The following is a description of a gene set: Any process that activates or increases the frequency, rate or extent of lipid localization. Mouse Gene Set: GOBP_POSITIVE_REGULATION_OF_LIPID_LOCALIZATION studied in species Mus musculus, and this is the list of marker genes: Nucb2, Ces1h, Ces1c, Washc1 (WASH complex subunit 1), Cyp4a31, Tac1, Abca1, Apoa1, Oxt, Scp2, Ces1d, Abcg4, Plin2, Ikbke, Lrat, Ces1f, Edn1, Avpr1b, Hrh3, Crh, Vstm2a, Runx1, Srebf2 (NCBI Gene Id 20788), Abcg1 (ATP binding cassette subfamily G member 1), Myb, Tnfrsf11a, Ldlrap1, Mapk9, Abca8b, Pla2g10, Zc3h12a, Pla2g4a, Pla2g3, Abca5, Asxl2, Pon1, Scarb1, Msr1, Atp8a2, Plin3, Zdhhc8, Ghrl, Ptch1, Nkx3-1, Dab2, Trem2, Ces1g, Nmb, Abca7 (NCBI Gene Id 27403), Apob, Lpl, Lpcat3, Atp8a1, Ces1b, Tnfsf11, Retn, C1qtnf1, Ntsr1, Dennd5b, Prap1, Acsl5, Nr1h3, Sirt1, Acsl1, Cyp2j5, Cd36, Erfe, Fabp3, Apoc4, Pla2r1, Pltp, P2ry2, Acsl6, Cyp4a32, Nfkbia, Xrcc4, Mif, Il1a, Galr1, Lrp1, Spp1, Ecrg4, Acacb, Abca8a, Ptges, Tmem135, Cav1, Map2k6, Nr1h2, Tmem30a, Pparg, Triap1, Bmp6, Anxa2, Pla2g6, Prelid1, Fasl, Abca12 (NCBI Gene Id 74591), Ces1e, Ces1a, Adipoq, Abcb4, Commd1, Osbpl11, Cyp4a10, Il1b, Abca13 (ATP-binding cassette, sub-family A member 13), Cyp19a1, Dbi, Gps2, Ehd1, Tmf1, Eepd1, Lipg, C3, Abca3, Hilpda (NCBI Gene Id 69573), Sstr4, Apoe, P2rx7, Nfkb1, Prkcd, Mfn2, Gal, Plin5